The following is a description of a gene set: species: Mus musculus Combining with prostaglandin E (PGE(2)) to initiate a change in cell activity. Mouse Gene Set: GOMF_PROSTAGLANDIN_E_RECEPTOR_ACTIVITY, and this is the list of marker genes: Ptger4, Hpgd, Ptger2, Ptger3, Ptger1